Given this list of marker genes WNT3, CTNNB1, FGF8, TFAP2B, TBX4, HOXD9, BMP4, RSPO2, RPGRIP1L, GPC3, ZBTB16, PITX2, WNT7A, PTCH1, SHH, BMPR1A, ALX4, MSX2, TWIST1, NOTCH1, MSX1, TP63, HOXD10, CHD7, ALX3 (NCBI Gene Id 93575), OSR2 (NCBI Gene Id 116039), TBX3, PITX1, GDF5, OSR1, MED1, LARGE1, FGF4 (fibroblast growth factor 4), RARB, AFF3, RARG, here is a description of the gene set: species: Homo sapiens The process in which the anatomical structures of the hindlimb are generated and organized. Human Gene Set: GOBP_HINDLIMB_MORPHOGENESIS